Given this list of marker genes Tff2, Gpr39, Nmu, Sct, Ptger3, here is a description of the gene set: Any process that decreases the rate frequency or extent of gastric secretion. Gastric secretion is the regulated release of gastric acid (hydrochloric acid) by parietal or oxyntic cells during digestion. Mouse Gene Set: GOBP_NEGATIVE_REGULATION_OF_GASTRIC_ACID_SECRETION species: Mus musculus